The following is a description of a gene set: FGFRL1 is a fifth member of the FGFR family of receptors. The extracellular region has 40% sequence similarity with FGFR1-4, but FGFRL1 lacks the internal kinase domain of the other FGF receptors and how it acts in FGFR signaling is unclear. Some models suggest FGFRL1 restricts canonical FGFR signaling by sequestering ligand away from kinase-active receptors, while other models suggest that FGFRL1 may promote canonical signaling by nucleating signaling complexes or enhancing ERK1/2 activation. part of: Signaling by FGFR1 studied in species Homo sapiens Reactome Pathway: FGFRL1 modulation of FGFR1 signaling, and this is the list of marker genes: FGF17, FGF10, SPRED2, FGF3, FGF2, FGF22, FGF8, SPRED1, FGFRL1, FGF5, FGF4, FGF18, FGF23